Given this list of marker genes AKR1A1, ACSM2B, MGST1, PCK1, CUBN, BBOX1, GLYAT (NCBI Gene Id 10249), CXCL14, MT1X, TSPAN1, ALDOB, DAB2, APOE, NAT8, C11orf54, MT1G, DPEP1, PDZK1, NEAT1, GLYATL1, KHK, RIDA, MT1F, ACSM2A, BHMT, SLC5A12, IL32, SPP1, LRP2, LGALS2, CRYAB, HAO2, TMEM176A, HPD, GSTA1, AKR1C3, OCIAD2, AZGP1, CLTRN, SMIM24, MT1H, MIOX, PDZK1IP1, RBP5, UGT2B7, GATM, PEPD, SLC3A1, SLC16A9 (solute carrier family 16 member 9), FABP1, here is a description of the gene set: from publication Gavish A, Tyler M, Greenwald AC, Hoefflin R, Simkin D, Tschernichovsky R, Galili Darnell N, Somech E, Barbolin C, Antman T, Kovarsky D, Barrett T, Gonzalez Castro LN, Halder D, Chanoch-Myers R, Laffy J, Mints M, Wider A, Tal R, Spitzer A, Hara T, Raitses-Gurevich M, Stossel C, Golan T, Tirosh A, Suvà ML, Puram SV, Tirosh I (PMID 37258682) studied in species Homo sapiens Human Gene Set: GAVISH_3CA_METAPROGRAM_EPITHELIAL_METABOLISM_KIDNEY_1 In this study, an extensive analysis was conducted to define meta-programs (MPs) capturing intra-tumor heterogeneity across a spectrum of tumor types. The approach utilized non-negative matrix factorization (NMF) to analyze each cell type separately within individual tumor samples. This involved the analysis of malignant cells, macrophages, fibroblasts, endothelial cells, epithelial cells, T-cells, and B-cells. NMF was executed with varying parameter values (K=4, 5, 6, 7, 8, 9), thereby generating 39 programs for each cell type per sample. Each NMF program was summarized by the top genes based on NMF coefficients.\nRobust MPs were then delineated for each cell type using a set of stringent criteria, including recurrence within the same tumor, similarity to programs in other tumors, and non-redundancy within a tumor. Subsequently, these robust NMF programs were clustered (per cell type) based on Jaccard similarity, leading to the identification of MPs associated with each cell type.\nTo enhance the quality of the MPs, a refinement steps were undertaken, involving the removal of MPs suspected of reflecting low-quality data (with an overrepresentation of ribosomal proteins or mitochondrial-encoded genes), single-study inclusion, or similarity to miss-annotated cell types. Genes upregulated in subsets of cells of a given type within various tumors